The following is a description of a gene set: studied in species Homo sapiens The process that results in the incorporation of a protein into a mitochondrial membrane. Human Gene Set: GOBP_PROTEIN_INSERTION_INTO_MITOCHONDRIAL_MEMBRANE, and this is the list of marker genes: OXA1L, TMEM126A, MOAP1, BCS1L, BAX, MAIP1, COX18